The following is a description of a gene set: studied in species Homo sapiens Human Gene Set: HP_ABNORMALITY_OF_THE_ENDOCRINE_SYSTEM An abnormality of the endocrine system. Abnormality of the endocrine system, and this is the list of marker genes: SOS2, UBE4B, PRSS2, DLL1, TTC7A, GNE, SQSTM1, RPL10L, PHF21A, POR, IQSEC2, CCND1, TMEM270, VANGL2, ZNF148, CTSH, CEL, ARID1B, HADHA, CLRN1 (clarin 1), BRCA2, TBCE, RAI1, TKT, TGFB1, RET (NCBI Gene Id 5979), HR, KCNE3, SAA1, NKX2-5 (NCBI Gene Id 1482), IL12A, ADA, VPS13B, GALT, VHL, DPF2, MT-ND2, KMT2A, DCAF17, MT-ATP6, NEUROD2, ATPAF2, CATIP, IFT74, PEX1, G6PC1, TMCO1, DIAPH2, RORC, PI4KA, TBX3, SLC3A1, GRM7, ABCC8, IFT56, CCDC47, MC2R, PHOX2A, NUP107, H4C5, PEX19, GCH1, FIGLA, PIGP, SH2B1, SASH1, TRAF3IP1, DNHD1, CDKN1A, SMO, CELA2A, MT-TQ, LMNA, PHKA2, RPGRIP1L, VSX1, ZBTB20, SMARCAL1, TSHR, ERCC6, BSCL2, GATA6, FAM111B, RRAS, NDUFV2, BUB3, LBR, SBDS, MGAT2, KISS1R, IFT88, RTL1, GNAQ, MPDU1, PNPLA6, MRAS, PCSK1, CHD8, KLHL7, MCM9, MSL3, MTHFR, CPA1, NLGN4X, TSC2, TRAPPC11, GATC, FOXP3, H6PD, GALNT2, EDA2R, POLG2, COQ2, DYRK1A, TDRD9, SOX5, PLAAT3, CTRC, SCAPER, ALG3, ZNF513, BEST1, SLC5A2, KLLN, PRDM16, BCS1L, IDH3B, HROB, KLHL3, SLC37A4, ESR1, PIGT, ZNF462, FSCN2, TLR8, TWNK, TYMS, TYMP, GJB2, COL4A5 (NCBI Gene Id 1287), CPE, QRSL1, TMEM216, BCOR, PDE6D, TBX2, STAG3, CEP120, AHSG (alpha 2-HS glycoprotein), KCNT1, TANGO2, USP9X, NFIX, BRAF, GNA11, SPATA22, POLD1 (DNA polymerase delta 1, catalytic subunit), COQ6, NEXMIF, ADAT3, ARVCF, USF3, NSMCE3, SHOC1, NOTCH3, ARID2, LIPE, CYP17A1, SPTBN1, PAX8, RP1, MKKS, SUGCT, GRB10 (growth factor receptor bound protein 10), MAX, POLR1D, FOXC1, TERC, PPP1R15B, DHDDS, TNXB, SRA1 (steroid receptor RNA activator 1), ADA2, PRKCZ, CYP27A1, MLXIPL, COMT, EIF2AK3, IL6 (interleukin 6), SMC3, SOX4, POLR3GL (NCBI Gene Id 84265), POLR3K, DNAH1, ASH1L, CDKN2B, HNRNPR, CILK1, B9D1, FAM20A, NDUFA1, SNRPN, NDUFB3, ALX4 (NCBI Gene Id 64068), AKT2, AP2S1, TMEM138, MCM8, FLRT3, PLEKHM1, SLC25A13, CUL4B, SPINK1, ALMS1, STK11, TMEM67, HFM1, SYCP3, SCN1B, AMHR2, FAH, FGD1, STAT3, EPO, FLI1, IFT172, KCNQ1, NEK2, CRELD1, DMPK, IL2RG, HNF4A, CBL, DDX3X (DEAD-box helicase 3 X-linked), ITPR1, POLR1C, TACR3, CTSK (cathepsin K), NSD1, EDA, NIPBL, PDPN, IFT27, STAT1, BMP2, LRAT, BBS7, NLGN3 (neuroligin 3), PLCG2, NCF1, SOST, DUOX2, GLI3, PEX11B, CP (NCBI Gene Id 1356), CASZ1, POF1B, VPS33B, HEPACAM, IL6ST (NCBI Gene Id 3572), TXNRD2, AKT1, ABCB11, DNA2, WNK1, FLCN, FGFR1, STX16, SCLT1, PLAA, HRAS, NODAL, GYG1, CYP24A1, CEP290, KDM6A, MMP1, SRCAP, AIP, RASA2, CAV1, PTCH1, MKRN3, IL2RA, HSD11B2, FBN1, TP53, GJB3, FSHB, NF1, MUTYH, PCYT1A, DCHS1, TTPA, CSPP1, MT-ATP8, TCF7L2, TDO2, IL12RB1, NDUFB11, FGFRL1, PLXND1, OCRL, EPAS1, MIR140, GJB4, TCOF1, RREB1, MT-CO2 (mitochondrially encoded cytochrome c oxidase II), PRDM10, ARMC5, DDB2, UBR7, SLC4A2, SGPL1, PDE6A, SEC24C, ATP5F1A (ATP synthase F1 subunit alpha), ZMPSTE24, STOX1, RGR, CHRNG, FAS, PPP1R3A, KATNIP, SLC35A2, NDUFA11, TBX1, VAMP7, TCF12, TMEM127, XPA, ITCH, TRAF7, TMEM231 (NCBI Gene Id 79583), SLC12A1, DNAJC3, LPIN2, SRPX2, KRAS, IRF5, NPAP1, FOXN1, GATA4, AEBP1, BRCA1, NDUFS7, TRIP13, NTN1, ESR2, PLVAP, ZNF668, KASH5, BNC1, TGFBR2, IRS1, IARS2, GPC4, WNT4, PEX26, STAT6, IFNG, CREBBP, AR, ARL6IP6, CIDEC, NDUFS8, LETM1, NDUFAF4, GPD2, PDE11A, NDUFB10, SLC34A1, ADGRG1, AGBL5, LEPR, PRPF31, RBM28, HGD, TRIM8, POU1F1, TUBB3, HERC2, SLC39A4, PSMC3IP, SNORD116-1, ARSL, MADD, FKBP6, MYH3, DSG1, COG2, BLK, HCRT, TAF4, ERCC1, EYA1, FOXD3, HLA-DQA1 (NCBI Gene Id 7946), APC2, CTNS, NDUFS3, MAK, NR1H4, SEMA4D, GNRH1, PPM1B, ASXL3, FOXL2, JAK1, ZFYVE26, NOP10 (NOP10 ribonucleoprotein), GHRHR, DMRT1, PRDM13, KCNAB2, HAMP, KIF21A, AIRE, WASHC5, SMC1A, PEX14, TCTN3, CDC42BPB, ERCC8, POLR3H (NCBI Gene Id 91605), ALG6, SUPT16H, PDX1, IGF1R, CASP10, FLT1, LIPA, HLA-DPA1, IFIH1, CLIP2, SIL1, TBL1X, SEMA4A, LRP4, WDR26, CBLB, OCA2, HBB, GRIN1 (glutamate ionotropic receptor NMDA type subunit 1), GNB2, EHMT1, DEAF1, ANTXR2 (NCBI Gene Id 118429), SIX2 (SIX homeobox 2), CLPP, FOCAD, SKIC3, ATP5F1E, XRCC2, NDUFB9, FREM2, SLC30A7, SMARCB1, RAF1, VPS35L, PRPS1, BBS12, IGSF1, ACP5, PRCD, MALT1, PNPLA2, SIX6, SMARCD1, METTL27, BBS2, FANCI, PDHA2, RAG2, PHKG2, YRDC, MT-TN, NKX2-1, TERB2, MEG3, ADAR, WIPF1, IGF2, LRP5, HACE1, ZIC2, ERCC3, MT-ND3, THRB, SLCO2A1, CDKN1C, TBCK, RP9, SERPINA6, CMPK2, LIFR, HFE, SRD5A2, PTF1A, CARS1, EIF5A, GK, DNM1L, PHGDH, SDHA, PIEZO1, STEAP3, NR4A2, NSMCE2, BBS4, PMS1, KIF1B, PLCB1, ABCB4, SLC26A4, PKD2, MSMO1, SCP2, TMEM237, FN1, LZTR1, WFS1, MKS1, AGPAT2, FOXA2, ADAMTSL1, CEP19, EPCAM, ERCC2, MAP3K1, SECISBP2, MT-TS2, SEMA3A, NHP2, EPG5, AXIN1, GHSR, SLC16A1, BTK, MRPS7, ARL13B, CDON, IGFALS, SALL1, GMPPA, NFKB2, FDX2, POLE, DCC, SMPD4, BCL10, NLRP1, NDP, HPD, TRMT10A, SMCHD1, G6PC3, ELMO2, ZFPM2, MPV17, CACNA1H, FOS, DNAH10, RAB3GAP2 (NCBI Gene Id 26114), SEC61A1, B3GLCT, YIPF5, NUBPL, ARHGEF18, PDCD10, ARMC9, TBC1D20, PAPPA2, EP300, RLBP1, AXL, MSH6, SLC25A11, DBH, BUB1, IMPDH1, FUT8, PRPF4, CD55, MERTK, FMR1, SOX11 (NCBI Gene Id 6664), SMARCA4, DKC1, CYP11B1, RNF212, MMP14, ITPR3, INS, LARS2, HADH, DUSP6, FXN, GPR161, VDR, KAT6B, KIAA0753, IGHG2, IRS2, PLIN1, LIPC, TFAP2A, GATB, MYT1L, USB1, CTLA4, NR3C2, TERB1, CWC27 (NCBI Gene Id 10283), TULP1, SPIB, WWOX, COL7A1, GJA1, CHD6, ENTPD1, SPRY4, CAMKMT, CAVIN1, PDGFB, TONSL, RAG1, FOXI1, REV3L, DIAPH1, SPOP, EFL1, GNB1, COL2A1, MTNR1B, USP48, FASLG, SLC2A2, OFD1, ABCA4, TCTN2, KLHL10, SLC35C1, ARMC12, SLC34A3, BUD23, KMT2B, ALG1, NR0B1, HNRNPK (NCBI Gene Id 3190), PHF6, SLC6A17, VIPAS39, PAX4 (paired box 4), ATP5MK, MIA3, DDOST, MT-ND6, FUCA1, RAB23, PTDSS1 (NCBI Gene Id 9791), IRX5, NDUFS1, IER3IP1, SCARB2, SPEN, VAX1, BICC1, DUOXA2, IMPG1, CCDC34, ADH5, GABRD, KDSR, SRD5A3, XPC, ROM1, CCDC141, MARS1, FOXRED1, ARNT2, ATP7B, NANOS1, BRCC3, FGF8, PLCH1, ZSWIM7, LTBP4 (latent transforming growth factor beta binding protein 4), BUB1B, NPHS1, SLC7A14, PDE4D, NECTIN1, LIN28B, KRIT1, ESCO2, SIK3, FANCL, FOXP1, GH1, MECP2, SKIC2, TSC1, GDF9, AQP2, PEX5, MARS2, WAS, GLUD1 (NCBI Gene Id 2746), DISP1, NAB2, RNASEH2C, LIMK1, GTF2IRD2, RHO (rhodopsin), TPO, HSD11B1, FANCA, FANCB, PALB2, AVPR2, PROKR2, ZNRF3, KISS1, SOHLH1, RAB18, INPP5E, HIRA, FAM111A, EIF2S3, ZEB2, P2RY11, DNAJC21, IL18BP, NRL, SOS1, TTC8, KCNJ1, PDE6G, GRIA1, MOG (myelin oligodendrocyte glycoprotein), DIO1, GCM2, ABCD1, IDH2, SIX5, DICER1, NR3C1, SMPD1, TTR, SIK1, CYP2R1, RRM2B, SPIDR, SLC32A1, NDUFAF5, SHH, DHH, CNGA1, SCN2A, PDE8B, NFS1, LUZP1, MRAP, CDKL5, SIX3 (SIX homeobox 3), SAG, RECQL4, ANKH, ERCC5, MST1, ZNF408, ADORA2A, PRIM1, NDUFAF1, MAPK8IP1, PMFBP1, KCNJ2, TP63, SCN1A, GLA, IYD, CLPB, EIF4H, CORIN, SLC25A4, RNU7-1, PROM1, PSTPIP1, SOX9, IMPG2, KMT2C, ANTXR1, MSH5, SNORD115-1, NEUROD1, CEP57, ZSWIM6, TBC1D7, SLC40A1, GLI2, USP8, MANF, LMF1, FRAS1, GPR35, NONO, STRADA, OPA1, KCNJ5, CCDC22, ATP6V1B2, PRLR, PHOX2B, CASK, ZNF365, KMT2D, IFT140, LSS, DHCR7, MMP23B, PROP1, RAP1B, SOCS1, IGF1, SMAD2, NDE1, NKX2-6, MMEL1, CERKL, PPP2R3C, LGR4, MEIOB, NDN, IL17RD, SIX1, FANCE, AAAS, ANOS1, RAC1, CHEK2, SCNN1G, IDH3A, POLG, CDC73, NSMF, LRP6, BAP1, USP7, KIZ (kizuna centrosomal protein), HPGD, BMP15, JAG1, GNRHR, POLR3B, BLM, TMEM126B (NCBI Gene Id 95018), CLDN19, CAT, CRIPTO, BBS5, MDH2, ACBD6, MT-ND4, NDUFAF2, ORAI1, NDUFS4, TFE3, SOX6, SRY, PIGQ, KCNJ11, STAR, KCNJ18, MT-ND5, MYCN, KLF1, PIBF1, SLC26A3, JMJD1C, MCOLN1 (NCBI Gene Id 57192), CYP21A2, GAN, NUAK2, BICRA, DDB1 (damage specific DNA binding protein 1), MINPP1, PROK2, TOGARAM1, PMS2, GOSR2, GCGR, PTPN22, MAST3, TAF4B, KCTD1, GHR, C1S, RETN (resistin), ALB, ALG9, AVP, PRSS1, WDR11, RERE, HNF1A, VPS37D, PREPL, PTH1R, ARL3, SYCP2L, TRAPPC9, SAMD9, NOTCH2, LHX1, ATP8B1, FEZF1, GLRX5, ZMYND15, CNOT1, CACNA1C, SEC23B, P4HA2, PSMB8, HID1, RFX6, UFD1, RNASEH2B, PRPF8, DDC, PCBD1, APOE, IMPDH2, MT-TW, CA4, MDM2, CCDC28B, SOX2, BBS10, FBXO43, SCNN1A, DUT, PLAG1, SLC19A2, CRX, SDHAF2, PEX10, RPE65 (NCBI Gene Id 6121), BMPR1B, SMAD4, GNAO1, HSD17B3, TEX15, CLDN10, POMGNT1, FANCD2, LAS1L, CHD7, PYGL, MT-TL2, COL25A1, ZNF526, HDAC4, GLIS3, DCLRE1C, SVBP, DGCR2, MT-TH, MRE11, LIG3, YY1, BAZ1B, ATP5F1D, CFTR (CF transmembrane conductance regulator), DLST, CNTNAP2, C1QBP, CA2, KEAP1, TRIP4, PDE6B, RNF125, CC2D2A, RNASEH2A, ZFP57 (NCBI Gene Id 642028), PTPN1, GALNT3, SPATA7, GANAB, PWAR1, GPR101, CCDC134, GP1BB, TF, NNT (NCBI Gene Id 23530), PSMD12, TRIM32, PTPN11, ERF, AMACR, MT-TC, HADHB, GALK1, RIN2, ENPP1, NF2, SMARCC2, CLDN16, NPM1, ALG14, ANK1, FOXC2, MAP2K1, MSH3, TNFSF15, BSND, SLC25A36, RCBTB1, STX1A, MED12, CFAP418, DYRK1B, BMPR1A, MCTP2, CTNNB1, CYP11A1, CCBE1, PDCD1, MAD1L1, SNRNP200, PAPSS2, HSPG2, SDHD, KIAA1549, SPAG17, ARID1A, SYCE1, IKBKG, SLC16A2, RNPC3, SLC5A5, RNU4-2, GCNA, RPS20, SLC12A5, MT-CO3, B9D2, MAP3K7, CLCN2, SDHC, RPGR, TGIF1, HGSNAT, ARL6, MSH4, DNMT3A, PRORP, PTRH2, IRF4, PPARG, VPS4A, SOX10, TBC1D24, HMGA2, UBR1, MMP2, NDUFAF8, LZTFL1, THPO, SASH3, ITGB6 (integrin subunit beta 6), RAB3GAP1, SPRED2 (NCBI Gene Id 200734), BRIP1, BBS1, APPL1, RAD51C, LRBA, EXOSC2, PHEX, TFR2, FGF13, HSD3B2, MCM4, HNF1B, DNAJB11, POLD3, IDH1, TBL2, STIL, PTH, CCM2, CHD4, ADRA2A, ATAD3A, TCF4, FSHR, MID1, WNT3, PUF60, PEX12, CDH23, YARS2, TRHR (thyrotropin releasing hormone receptor), PWRN1, MDM4, PRKAR1A, DNASE2, MRPS25, CDKN2A, NDUFS6 (NADH:ubiquinone oxidoreductase subunit S6), STUB1, PRPH2, FAM161A, SCNN1B, MICU1, TSHB, CYB5A, LMNB2, KDM1A, MT-ND1, TIAM1, SP110, NFKBIA, CYP3A4, RFC2, UBE2T, CASR, FAT4, BBS9, XRCC4, RNF113A, CRLS1, FH, NSD2, POLA1, IGF2BP2, SLF2 (NCBI Gene Id 55719), HTR1A, HJV, TBX19, IGKC, STAG2, TUBB2B, BIRC3, SLC25A22, TUB, ALG5, NAF1, NEUROG3, SMC5, SMARCE1, MAGEL2, MAMLD1, POLR3A, TINF2, DPYSL5, NDUFAF3, GNAS, AMH, TIMMDC1 (translocase of inner mitochondrial membrane domain containing 1), SPRTN, LHB, MLH1, HYMAI, PRPF3, ATRX, CBX2, RIT1, OTX2, ALG2, PEX6, SIM1, GPC3, AHR, NSUN2, ALG8, RNU4ATAC, TREX1, GTF2I, CACNA1D, BMP6, SLC12A3, EIF2B1, WT1, BTG4, C14orf39, BRD4, ATM, HDAC8, ABCC6, WRAP53, LIG4, PLAGL1, ZFX, RAD21, PEX16, HESX1, APOA5 (NCBI Gene Id 93561), PDGFRB, LMO1, BPTF, FANCM, ADNP, TNFSF4, CTDP1, CPLX1, RTEL1, GRIN2B, SAMHD1, B4GALNT1, SLX4, SUFU, NLRP3, NR2F2, MT-CYB, HS6ST1, IRS4, PIK3CA, MAB21L2, LHCGR, CYP11B2, ADCY3, SPI1, DGCR8, MRPS22, SIN3A, ADCY5, SNAP29, NIN, DHX38, APC, RP1L1, MT-TK, MSH2, MGME1 (mitochondrial genome maintenance exonuclease 1), CDKN2C, MCM10, ERCC4 (ERCC excision repair 4, endonuclease catalytic subunit), WNK4, FLII, MC4R, SLC30A8, TERT, GUCA1B, PRKACA, RPL10, CBY1, CEP112, RMRP, UMOD, ALK, STS, TOPORS (TOP1 binding arginine/serine rich protein, E3 ubiquitin ligase), CDKN1B, PCNT, MT-TE (mitochondrially encoded tRNA-Glu (GAA/G)), MTTP, NDNF, CEP104, NR5A1, AHI1, ROBO1, CPLANE1, ALG12, PIK3C2A, HSD17B4, TUBA1A, KANSL1, THOC2, BCAP31, RBP3, CDC42, REEP6, RAD51, SKI, SDHB, WDR4, GREM1, PNLDC1, MSTO1, FILIP1, TAC3 (NCBI Gene Id 6866), GNAS-AS1, CNGB1, DNMT1, PCARE, SDCCAG8 (NCBI Gene Id 10806), PRTN3, TAF13, PGM1, WRN, TEX14, AFF4, GMNN, PPOX, CACNA1S, GBA1, LHX3, KCNJ16, CENPT, LEP, PEX3, HMGA1, TMEM218, HLA-DRB1, PARN, KLF11, THRA (thyroid hormone receptor alpha), USH2A, LHX4, GAS1, KCNJ10, HABP2, SUN5 (NCBI Gene Id 140732), DNAJC30, PLCD1, BTNL2, FREM1, ALDOA, MEF2A, NDUFS2, NPHP1, PRPF6, KCNA1, KCNQ1OT1, FANCF, EXT2, FOXH1, CNBP, IARS1, PRNP, ZNF423, NR2E3, PEX2, ACTG2, DGCR6, GCK, CYP19A1, MOV10L1, NDUFV1, TRPV6, DIS3L2, SEMA3E, ZFAT, KARS1, POC1A, HLA-DQB1, FANCC, PIGA, DNAL4, PIGF, KCNJ6, MAP2K2, TNPO3, TAF6, SLC7A7, PTCH2, CRB1, SRGAP1, PNKP (NCBI Gene Id 11284), CTC1, IL7R, SETBP1, HLA-DPB1, GFM2, MAB21L1, HLA-B, ESS2, FOXE1, MT-TF, SOX3, TEX11, CDHR1, INSR, DLK1, ANAPC1, MT-CO1, LSM11, RNF216, DNAJC19, BANF1, CEP41, FLNB (NCBI Gene Id 8413), DACT1, NEK9, FGF17, DHX37, NSDHL, TCTN1, GABRA3, RP2, ARX, PITX2, MPI, BMP4, PEX13, WDPCP, TNRC6B, EYS, FANCG, MAD2L2, NRAS, HYLS1, SCN4A (sodium voltage-gated channel alpha subunit 4), ELN, CLCNKB, MAFA, KIAA0586 (NCBI Gene Id 9786), BBIP1, POU2AF1, MOGS, B4GALT1, STAT5B, CLCNKA, PRMT7 (protein arginine methyltransferase 7), LEMD3, TG, KL, MEN1, SLC29A3, PIK3R1, PMM2, RABL3, RDH12, PUS1, RRAS2, MAGED2, CUL3, POLR1B (RNA polymerase I subunit B, NCBI Gene Id 88998), RFWD3, PKD1, MT-TL1, CISD2, GATA3 (GATA binding protein 3), UCP2, POMC, POU3F4, NDUFA6, ARL2BP, GTF2IRD1, PALLD, FARSA, PTEN, TRH, AK2, ATP11A, DMXL2, NHLH2, IPO8, MT-TV, SHROOM4, CYP27B1, KCNQ2, SARS2, ALX3, CTBP1, CT55